The following is a description of a gene set: Human Gene Set: GSE18791_UNSTIM_VS_NEWCATSLE_VIRUS_DC_10H_DN The dendritic cell (DC) is a master regulator of immune responses. Pathogenic viruses subvert normal immune function in DCs through the expression of immune antagonists. Understanding how these antagonists interact with the host immune system requires knowledge of the underlying genetic regulatory network that operates during an uninhibited antiviral response. In order to isolate and identify this network, we studied DCs infected with Newcastle Disease Virus (NDV), which is able to stimulate innate immunity and DC maturation through activation of RIG-I signaling, but lacks the ability to evade the human interferon response. To analyze this experimental model, we developed a new approach integrating genome-wide expression kinetics and time-dependent promoter analysis. We found that the genetic program underlying the antiviral cell state transition during the first 18-hours post-infection could be explained by a single regulatory network. Gene expression changes were driven by a step-wise multi-factor cascading control mechanism, where the specific transcription factors controlling expression changed over time. Within this network, most individual genes are regulated by multiple factors, indicating robustness against virus-encoded immune evasion genes. In addition to effectively recapitulating current biological knowledge, we predicted, and validated experimentally, antiviral roles for several novel transcription factors. More generally, our results show how a genetic program can be temporally controlled through a single regulatory network to achieve the large-scale genetic reprogramming characteristic of cell state transitions. Genes down-regulated in comparison of control conventional dendritic cells (cDC) at 10 h versus cDCs infected with Newcastle disease virus (NDV) at 10 h. from publication Zaslavsky E, Hershberg U, Seto J, Pham AM, Marquez S, Duke JL, Wetmur JG, Tenoever BR, Sealfon SC, Kleinstein SH (PMID 20164420) studied in species Homo sapiens, and this is the list of marker genes: GADD45B, ISG20, ARHGAP27, ARGLU1-DT, SAMD9, IFNA2, PHF11, SARDH, EPSTI1, EXTL2, RSAD2, DOK7, VSIG1, PJVK, MX1, MMP14, PARP14, DHX58, ETV7, OASL, FUT4, DDX60, NRIP1, KCNJ2, OSR2, SYNPO2, OAS3, IL6, SP110, GPR180, CASP10, HIVEP2, IFIT3, HELB, ZBP1, IFNW1, APOL6, CCDC181, TNFSF10 (NCBI Gene Id 8743), AIM2, RTCB, ADAR, ZC3HAV1, NECTIN2, ATP10A, TRIM5, SRGAP2, SLFN5, TRIM22, GBP5, FAS, CXCL1, ADGRE1, IFNA10, AKAP7 (A-kinase anchoring protein 7), ISG15, IL15RA, IFIT2, TGM1, ISCA1, PNPT1, MCUB, CARD16, DYNLT1, PLSCR1, TTF2, GTF2B, ARID5A, IFIT5, PDE4B, CXCL10, OAS2, DTX3L, MYD88, MFN1, PTGS2, TAP1, HERC6, ARHGEF11, CASP5, IFIH1, ANXA2R-AS1, C21orf91, IFNL2, ABTB2, STAT1, HEXD (NCBI Gene Id 284004), IRF7, CCDC13-AS2, UBE2Z, PAXIP1-AS2, USP18, HELZ2, MAP3K8, CXCL9, CSRP2, NFKBIZ, STX11 (syntaxin 11), HERC5, CD38, STAT2, IFNA8, SLC31A2, TOR1B, PABIR3, NT5C3A, MASTL, ASB10, ENTHD1, SIGLEC1, BRIP1, RGL1, FAM43A, JADE2, SHFL, IFI44, BATF2, SASH1, CXCL11, ARL5B, ITIH4, CNP, SAMD9L, STARD5, PMAIP1, GSTM3, TMEM19, FGFR3, SP140L, EFEMP2 (EGF containing fibulin extracellular matrix protein 2), MX2, ALPK1, GBP4, LYSMD2, CYP1A1, SECTM1, TNF, ZNFX1, RIPOR2 (RHO family interacting cell polarization regulator 2), NEXN, FAM111A, PHACTR4, PDGFRL, XAF1, MEIS1, SELENOI, KIR2DL5A, IFI6, NAA25, IL10RA, TLK2, RIGI, ZNF32-AS3, PML, LGALS3BP, IER2 (immediate early response 2), CMPK2, PARP9, B3GNT4, CMTR1, IDO1, SERPING1, CELSR3, MAML2, IFI44L, RNF43, UBA7, CXorf38, CARINH, TRIM69, XPO6, NEDD9, IFNL1, TLR3, IFNA14, SP100, PI4K2B (phosphatidylinositol 4-kinase type 2 beta), APOL1, WARS1, USP6NL, TMEM268 (NCBI Gene Id 203197), TRIM26, PGAP1, TRIP4, BCL2L14 (BCL2 like 14), PSMA4, GCH1, NEURL3, FGFBP3, APOBEC3G, CASK, IFNB1, RTP4, HBM, IFNA7, TENT4A, IFNA16